Given this list of marker genes DST, PAK6, IQGAP1, PAK2, VANGL1, USP9X, CDC42, EPHA2, SPTAN1, TPM4, CLTC, MYO9A, DEPDC1B, RHOV, GIT2, TPM3, GIT1, PAK1, WDR6, DLG5, PAK4, ARHGAP12, PARD6B, WASL, MAP3K11, ARHGEF7 (NCBI Gene Id 8874), CEP97, NCK1, NCK2, CCP110, ZNF512B, TXNL1, SPTBN1, SH3RF1, PEAK1, PARD6A, PIK3R1, here is a description of the gene set: part of: RHO GTPase cycle species: Homo sapiens RHOV (also known as Chp) is an atypical RHO GTPase that is thought to be constitutively active due to its high intrinsic guanine nucleotide exchange activity. No guanine nucleotide exchange factors (GEFs) nor GTPase activator proteins (GAPs) that act on RHOV have been identified. RHOV is expressed at very low levels. The expression of RHOV is detected during embryonic development in fish, frog and chicken. RHOV is involved in neural crest formation, where its expression is induced downstream of WNT signaling. RHOV is thought to regulate cell adhesion, as its zebrafish orthologue is required for proper localization of E-cadherin and beta-catenin at adherens junctions. RHOV activates JNK and induces apoptosis in rat pheochromocytoma cell line PC12 and in macrophages.<br><br>RHOV gene overexpression is a molecular marker of human lung adenocarcinoma, where RHOV is likely to act as an oncogene.<br><br>For review, please refer to Faure and Fort 2015, and Hodge and Ridley 2020. Reactome Pathway: RHOV GTPase cycle